Given this list of marker genes HMGCS2, ACLY, CS, CLYBL, HMGCS1, here is a description of the gene set: species: Homo sapiens Catalysis of the transfer of an acyl group from one compound (donor) to another (acceptor), with the acyl group being converted into alkyl on transfer. Human Gene Set: GOMF_ACYLTRANSFERASE_ACTIVITY_ACYL_GROUPS_CONVERTED_INTO_ALKYL_ON_TRANSFER